The following is a description of a gene set: species: Homo sapiens from publication Knell J, Best JA, Lind NA, Yang E, D'Cruz LM, Goldrath AW (PMID 23325888) Genes down-regulated in KLRG1 low CD8 T effector cells during infection: wildtype versus ID2. Human Gene Set: GSE41978_WT_VS_ID2_KO_KLRG1_LOW_EFFECTOR_CD8_TCELL_DN CD8+ T cells play a crucial role in the clearance of intracellular pathogens through the generation of cytotoxic effector cells that eliminate infected cells and long-lived memory cells that provide enhanced protection against reinfection. We have previously shown that the inhibitor of E protein transcription factors, Id2, is necessary for accumulation of effector and memory CD8+ T cells during infection. Here we show that CD8+ T cells lacking Id2 did not generate a robust terminally-differentiated KLRG1hi effector population, but displayed a cell-surface phenotype and cytokine profile consistent with memory precursors, raising the question as to whether loss of Id2 impairs the differentiation and/or survival of effector-memory cells. We found that deletion of Bim rescued Id2-deficient CD8+ cell survival during infection. However, the dramatic reduction in KLRG1hi cells caused by loss of Id2 remained in the absence of Bim, such that Id2/Bim double-deficient cells form an exclusively KLRG1loCD127hi memory precursor population. Thus we describe a role for Id2 in both the survival and differentation of normal CD8+ effector and memory populations., and this is the list of marker genes: MERTK, TSHZ2, PPP3CC, NDFIP2, MTARC2, BCL2, CAMKK1, NEDD4L, CCND2, ARMCX3, PSMA6, STARD13, SNHG6, SLC15A4, SMYD2, MME, TIMM50, LAMP1, STRA6, MXD1, CFTR (NCBI Gene Id 1080), EAF2, NSMCE1, CHI3L1, MMP17, TCTN2 (NCBI Gene Id 79867), HES3 (hes family bHLH transcription factor 3), JAG2, NFIL3, CLIP2, SH3BGRL2, HOXB2, ENPP4, LRRC8C, HDLBP, ITGAV, UBL3, FBLN5 (NCBI Gene Id 11268), SERPINE1, MYL10, CRABP2, CLCN3, RIT1, PDE3A, RAB3B, CKB, ELL, SMC5, APCS, LHX1, UBTD1, NEDD9, AKT3, IFT57, FMNL3, ARHGAP17, MVP, GNG12, UMOD, ALDH1A3, CNDP2, DUOXA1, DHRS3, MAFG, FGF9, NMUR1, MAT1A, HIP1, ACTRT1, TMEM45A, PCDHB5, MYC, MTMR3, KMO, P2RX4, TGM1 (NCBI Gene Id 7051), SRGN, KLF9, NID2, UBE2O, BASP1, TMPRSS11D, HECTD1, CHST14, ADRB3, PDCD10, ACBD3, ELMO1, FBXW4, KIF3A, SMC1B, CFLAR, KCND2, KRT20, RNF6, RIPK4 (NCBI Gene Id 54101), NRBF2, ZNF707, SMAD3, CNOT7, LAMA5, IL4R, RBPMS2, SRD5A3, TMEM37, NDUFS4, XPNPEP1 (X-prolyl aminopeptidase 1), PIWIL2, SUCO, KCNE4, NDST1, RAI14, CDHR1, FHL2, CUBN, NDEL1 (NCBI Gene Id 81565), PAXBP1, PLCB2, WARS1, SORCS2, FGD2, CCRL2, TYW5, HCN3, KDF1, CSGALNACT1, NT5E, ARL4A, DOCK7 (dedicator of cytokinesis 7), PDE8A, HIC1 (HIC ZBTB transcriptional repressor 1), FOS, GUCA1A, TRIP12, RPN2, LGALSL, CCL24 (NCBI Gene Id 6369), FCGR1A, PIP5KL1, SEMA3B, AK2, LZTFL1, CYP4A22, HRC, GPR146, SNX18, H2BC5, SLC15A5, CIAO2B, NRSN1, KCNK5, LRRC18, ITGA4, FBXW11, UQCR11, NFKB1, PTGER3, ESPN, GYS1, SPRED2, SH3RF1, BCR, EN2, ADAM19, WNK1, CA12, PIM1, P2RX7, UTF1, MLPH, RNF5, LY86, MEIS2, POLR3K, BDKRB1, NID1, TMEFF1, RNF126, FFAR2, GCNT2, ME1, GSPT2, NOCT, PCOLCE2, CACNG1, ZFP91, DTX1, FBXL14, TGM2, C6orf120, CEP104, NAMPT, HK2, INPP5B, POF1B, CRISPLD1, OSGIN1, THBS4, CALB1, PLK3